The following is a description of a gene set: Antigen processing-Cross presentation studied in species Mus musculus Mouse Gene Set: REACTOME_ANTIGEN_PROCESSING_CROSS_PRESENTATION, and this is the list of marker genes: Mrc1, Psmc5, Psma6, Psmc4 (proteasome (prosome, macropain) 26S subunit, ATPase, 4), Psmb3, Psmb10, Ncf2, Psmd1, Psmd11, Psma5, Fcgr1, Psmd2, Stx4a, Psma4, H2-M10.6 (NCBI Gene Id 399549), Psmb5, Psmb8, Ncf1, Psmc2, H2-M10.3, Psma7, H2-M11, H2-M9, H2-M10.5, Psmb7, H2-M5, Snap23, Psmd6, H2-M10.4, Cd207, Psmb4, Psmc1, Psma2, Psma1, H2-M10.2, Psma3, Psmd7, Tapbp, H2-T22, Adrm1, Psmd12 (NCBI Gene Id 66997), Psmb2, Cd36, H2-Q6, Psmd13, H2-M10.1, Lnpep, Itgav, Psmc6, H2-K1, Psme1, Pdia3, Psme2, H2-T10, Cybb, Vamp3, Psmc3, Psmb1, Psmb6, Psmd8, B2m, H2-Q10, Ncf4, H2-M1, H2-M3, Tap2, H2-Q7, Psmd3, Psmd14, Cyba, Tap1, Psme2b, H2-Q4, Calr, H2-T23, Sec22b, Mrc2, H2-Q2, Vamp8, H2-Q1, H2-M2 (histocompatibility 2, M region locus 2)